Given this list of marker genes CHUK, PELI3, TRAF6, IRAK1, RPS27A, PELI2, IKBKB, IKBKG, UBA52, UBC, UBE2V1, UBB, PELI1, UBE2N, here is a description of the gene set: part of: MyD88 cascade initiated on plasma membrane; MyD88:MAL(TIRAP) cascade initiated on plasma membrane Reactome Pathway: IRAK1 recruits IKK complex species: Homo sapiens The role of IRAK1 kinase activity in the activation of NF-kappa-B by IL-1/TLR is still uncertain. It has been shown that a kinase-dead IRAK1 mutants can still activate NF-kappa-B. Furthermore, stimulation of IRAK1-deficient I1A 293 cells with LMP1 (latent membrane protein 1- a known viral activator of NF-kappa-B) leads to TRAF6 polyubiquitination and IKKbeta activation. On the other hand, IRAK1 enhances p65 Ser536 phosphorylation and p65 binding to the promoter of NF-kappa-B dependent target genes.<p> IRAK1 has also been shown to be itself Lys63-polyubiquitinated (probably by Pellino proteins, which have E3 ligase activity). Mutation of the ubiquitination sites on IRAK1 prevented interaction with the NEMO subunit of IKK complex and subsequent IL-1/TLR-induced NF-kappa-B activation. These data suggest that kinase activity of IRAK1 is not essential for its ability to activate NF-kappa-B, while its Lys63-polyubuquitination allows IRAK1 to bind NEMO thus facilitating association of TRAF6 and TAK1 complex with IKK complex followed by induction of NF-kappa-B. </p><p>Upon IL-1/TLR stimulation IRAK1 protein can undergo covalent modifications including phosphorylation, ubiquitination and sumoylation. Depending upon the nature of its modification, IRAK1 may perform distinct functions including activation of IRF5/7, NF-kappa-B, and Stat1/3.